Given this list of marker genes SNX27, WASHC1, TBC1D23, WASHC4, DNAJC13, WASHC5, CAPZA1, WASHC2A, CAPZB, WASH6P, RCSD1, WASH3P, WASHC2C, WIPF3, WASHC3, here is a description of the gene set: A protein complex that localizes at the surface of endosomes, where it recruits and activates the Arp2/3 complex to induce actin polymerization. In human, the WASH complex is composed of F-actin-capping protein subunits alpha and beta, WASH1, FAM21, KIAA1033, KIAA0196 and CCDC53. Human Gene Set: GOCC_WASH_COMPLEX species: Homo sapiens